The following is a description of a gene set: studied in species Homo sapiens Any process that stops, prevents or reduces the frequency, rate or extent of hepatocyte apoptotic process. Human Gene Set: GOBP_NEGATIVE_REGULATION_OF_HEPATOCYTE_APOPTOTIC_PROCESS, and this is the list of marker genes: PPARA, ADAR, RB1, PRKAA2, CFLAR, PRKAA1